The following is a description of a gene set: The volume enclosed by the membranes of a microbody. Human Gene Set: GOCC_MICROBODY_LUMEN studied in species Homo sapiens, and this is the list of marker genes: CRAT, AGPS, NUDT19, NOS2, POMC, PRDX5, GSTK1, EPHX2, ACOT4, CRYM, BAAT, TYSND1, PEX7, AMACR, PEX5, CAT, ECH1, ECI2, HAO1, ATM (ATM serine/threonine kinase), GRHPR, EHHADH, HMGCL, SCP2, MLYCD, ACOXL, GNPAT, PAOX, ACAA1, IDE, HACL1, DDO, FABP1, CROT, PIPOX, ACOX3, ACOT2, ACOX2, NUDT7, DAO, NUDT12, HSD17B4, ABCD3, AGXT, IDH1, LONP2 (NCBI Gene Id 83752), HAO2, ACOX1, ACOT8, PHYH, DHRS4